The following is a description of a gene set: species: Homo sapiens Reactome Pathway: Mismatch Repair part of: DNA Repair The mismatch repair (MMR) system corrects single base mismatches and small insertion and deletion loops (IDLs) of unpaired bases. MMR is primarily associated with DNA replication and is highly conserved across prokaryotes and eukaryotes. MMR consists of the following basic steps: a sensor (MutS homologue) detects a mismatch or IDL, the sensor activates a set of proteins (a MutL homologue and an exonuclease) that select the nascent DNA strand to be repaired, nick the strand, exonucleolytically remove a region of nucleotides containing the mismatch, and finally a DNA polymerase resynthesizes the strand and a ligase seals the remaining nick. <br>Humans have 2 different MutS complexes. The MSH2:MSH6 heterodimer (MutSalpha) recognizes single base mismatches and small loops of one or two unpaired bases. The MSH2:MSH3 heterodimer (MutSbeta) recognizes loops of two or more unpaired bases. Upon binding a mismatch, the MutS complex becomes activated in an ATP-dependent manner allowing for subsequent downstream interactions and movement on the DNA substrate. (There are two mechanisms proposed: a sliding clamp and a switch diffusion model.) Though the order of steps and structural details are not fully known, the activated MutS complex interacts with MLH1:PMS2 (MutLalpha) and PCNA, the sliding clamp present at replication foci. The role of PCNA is multifaceted as it may act as a processivity factor in recruiting MMR proteins to replicating DNA, interact with MLH1:PMS2 and Exonuclease 1 (EXO1) to initiate excision of the recently replicated strand and direct DNA polymerase delta to initiate replacement of bases. MLH1:PMS2 makes an incision in the strand to be repaired and EXO1 extends the incision to make a single-stranded gap of up to 1 kb that removes the mismatched base(s). (Based on assays of purified human proteins, there is also a variant of the mismatch repair pathway that does not require EXO1, however the mechanism is not clear. EXO1 is almost always required, it is possible that the exonuclease activity of DNA polymerase delta may compensate in some situations and it has been proposed that other endonucleases may perform redundant functions in the absence of EXO1.) RPA binds the single-stranded region and a new strand is synthesized across the gap by DNA polymerase delta. The remaining nick is sealed by DNA ligase I (LIG1).<br>Concentrations of MMR proteins MSH2:MSH6 and MLH1:PMS2 increase in human cells during S phase and are at their highest level and activity during this phase of the cell cycle. Defects in MSH2, MSH6, MLH1, and PMS2 cause hereditary nonpolyposis colorectal cancer (HNPCC, also known as Lynch syndrome)., and this is the list of marker genes: MLH1, MSH3, POLD1, RPA2, POLD2, POLD3, RPA1, PCNA, EXO1, POLD4, MSH6, PMS2, RPA3, MSH2 (mutS homolog 2), LIG1